Given this list of marker genes DUSP10, DUSP4, DUSP8, DUSP2, DUSP9, DUSP16, DUSP7, DUSP6, here is a description of the gene set: species: Homo sapiens Human Gene Set: GOMF_PROTEIN_TYROSINE_THREONINE_PHOSPHATASE_ACTIVITY Catalysis of the reactions: protein threonine phosphate + H2O = protein threonine + phosphate; and protein tyrosine phosphate + H2O = protein tyrosine + phosphate.